The following is a description of a gene set: from publication Chen Y, Wang X (PMID 31504780) Human Gene Set: MIR152_5P studied in species Homo sapiens Genes predicted to be targets of miRBase v22 microRNA hsa-miR-152-5p in miRDB v6.0 with MirTarget v4 prediction scores > 80 (high confidence targets)., and this is the list of marker genes: EDEM1, PANK2, ANO3, NBPF14, RBMS3, B4GALNT1, RREB1, LYN, EOGT, LTBP2, PABIR3, TMEM117, PIK3C2A, TRPM1, FRMD6, FBXO46, PREPL, NAP1L1, KCTD12, SLC6A15, NBPF9, UBN1, NBPF8, CLVS1, ONECUT2, RPS6KA6, CAMKK2, TUT4, PGGT1B, CREBRF, MFAP4, ENPEP, ADGRG6, TMEM150A, FAM107B, ARHGAP6, NAA30, DDAH2, NBPF15, NBPF3, SMPD3, SEC24D, NBPF11, NBPF12, POTEA, KRT4, C21orf58, TNFSF10, CC2D2A, VAMP3, ARL4C, POTEC, PHACTR2, FYCO1, LARS1, CRIM1, POLR2L, TCEAL5, NID2, NBPF20, GTF2H1, NBPF1, ZC3H6, SLMAP, ZNF410, NEXN, EARS2, AK7, FAM219B, HERC4, ELP1, ZNF281, UNC13C (NCBI Gene Id 440279), PHKA1, METTL13, KCNJ4 (NCBI Gene Id 3761), SNAI3, EYA3, CLOCK, TSPAN3, MED13L, PLEKHS1, CHM, TAFAZZIN, PDS5A, ILDR2, GLI3, CABP1, POU4F1, KLHL23, KPNA6, RALGPS1